The following is a description of a gene set: from publication Chen Y, Wang X (PMID 31504780) Human Gene Set: MIR10527_5P species: Homo sapiens Genes predicted to be targets of miRBase v22 microRNA hsa-miR-10527-5p in miRDB v6.0 with MirTarget v4 prediction scores > 80 (high confidence targets)., and this is the list of marker genes: SHOC2, AEBP2, DMRTA2, MAP2K3, ST3GAL2, SH3BGRL2, NECAP2, RCC2, TRA2A, ANKS1B, NFAT5, CXXC4, PIGA, CHL1, SPIN1, CTTNBP2, RAB3C, GLRA2, MLEC, GABRB2, KCTD9, ARPP19, C2CD6, TMEM201, CNTN4, FAP (fibroblast activation protein alpha), C2orf69, PARVA, C5orf15, LRTM1, KICS2, KDM7A, CUX1 (cut like homeobox 1), FLVCR1, MYOZ2, SAMD9L, MCM6, TNRC6B, EXOC5, DSTN, NRIP1, SP1, PRR14L, ZNF17, PTP4A1, POLR2K, MYLK4, SH3KBP1, SLC6A6, SUDS3, CACNA1C, FBXW8, SIPA1L2, PDE10A, AAK1, SLC25A24, FIBIN, USP34, TBC1D9, HSPH1, LONRF1, B3GNT5, SSTR1, SGIP1, TMTC4, BOLL, SPTSSB, BET1, ZNF445, FOS, CADM2, SLC2A2 (solute carrier family 2 member 2), CNTRL, OGFRL1, ATXN3, ASTN1, PKD2L2, GTF2H5, VAV3, ATP2A2, SAXO2, TOX3, KLF6, ANKRD50, PPP1R9A, MN1, ZC3HAV1L, DUT, ABHD2, BARX2, DPY19L1, TRDN, STON1, PCNX1, AFF1, ZFR, NIPSNAP3B, USP42, PJA2, PHF14, FSD1L (NCBI Gene Id 83856), TBRG1, SETD7, RO60, SCAI, PLS3, SFT2D1, FRMD6, PROX1, BMI1, B4GALT6, SEMA3E, CTTNBP2NL, LAPTM5, C14orf39, PELI1, LMO7, PBX3, APAF1, CMTM6, HAT1, TAFA2, EPS8, SBNO1, ADAM10, CYP7A1, CMPK1, NIBAN1, IDS, PMP22, IRF2BPL, CSNK1G3, MACC1, TUSC3, LMO3, FAM53C, IRF2BP2, ZMAT3, CCDC18, ERAP1, ELAVL1, TMEM248, MSRB3, SLITRK4, ZFAND5, SDC1, ADAMTS6, IRF6, FGFR2, LBR, PRICKLE2, RPS6KA6, LAMP2, SUSD6, ZFP91, RFX3, CDK17, APOL6 (apolipoprotein L6), HYCC2, DCP2, PKHD1, NAV1, CSTF2, GRIA2, AKAP11, TRPC5, GTF2A1, SMIM14, PILRB, DOCK11, MS4A7, AGPAT5, SEPTIN11, CLEC3A, SLC35B4, RNPS1, SELENOF, MAP2K1, SPICE1, STK17B, MAST4, PREPL, COLEC11, FAM72A, STOML3, MYBL1, FSTL1, DNM3, UBE2K, ADNP, NAP1L4, ESCO2, ZNF527, TNIP1, ESRRG, PPM1D, PAN3, KCNK10 (potassium two pore domain channel subfamily K member 10), MAP3K2, MIGA1, TET3, NEBL (nebulette), HLA-DOA, SURF4, TNF, KCNJ5-AS1, OSBPL6, CMPK2, PCGF5 (NCBI Gene Id 84333), LIN54 (NCBI Gene Id 132660), C1orf56, OPTN, ITPRIPL2, ADNP2, MARCHF6, PLAGL2, MAFB, HNRNPD, UBE3A, CLIP4, ZIK1, PTGFRN, PPP3R1, C1RL, APPL1, BCL11B, CTBS, KATNBL1, MTMR10, CCDC88A, MTF1, GOSR2, CTCF (NCBI Gene Id 10664), HIVEP2, MYOCD, MBNL1, KSR1, MAF, IDE, CELF2, PRRX1, LRRN1, DOCK4 (dedicator of cytokinesis 4), SBSPON, ZNF319, PXK, BAMBI, TOR1AIP2, VPS13C, SRPK2, SELENOT, UBP1, CASP8AP2, YBX3, SOBP, KERA, RAB22A, HAUS2, SEC61A1, PGR, ZNF367, DAB2IP (DAB2 interacting protein), MCTP2, PLCXD3, RYBP, CNOT6, TIAL1, CA5B, FAM72C, ZNF267 (zinc finger protein 267), UCMA, TAFA1, ZNF407, FAN1, FAM72D, PURA, SPATS2L, MKLN1, CERT1, TENT5A, TCAIM, MEF2C, RAB14, TAF12, CSDE1, ANKRD63, RAB18, POLR2M, ZFHX4, EAF1, POLR1F, IPPK, CFAP300, PPP1R1C, PHACTR2, EGR4, PMP2, STK39, MAPK1, WAPL, SNX16, KCND2, CERS3, FAM72B, AMMECR1, CDK14, YOD1, CBLN1, ADRA1A, EZR, PPIC, RMND5A, NR4A3, RNF19A, GCOM1, STXBP5, GAD1, LRIG2, ETV1 (NCBI Gene Id 221810), SYPL1, MRAP2, ONECUT2, PRDM1, ACER3, CDH12, DGKG, THBS1, USP24, TMEM243, PAPOLA, DTNA, SYNJ2BP, PLXDC2, ZNF704, DENND1B, MID1, SORBS2, COMMD3-BMI1, TSHZ3, TXLNG, CDKN1B, MBD2, CFAP91, NRG1 (neuregulin 1), NAA50, MON2, CA8, ZNF404 (NCBI Gene Id 342908), LACTB2, DIP2A, LZTS1, IP6K2, MIER1, EBF2, CDK2AP1, BPTF (bromodomain PHD finger transcription factor), MFAP3L, CEP57, SLC6A4, ERCC6, AMER2, MATN3, PATE3, RXRA, SLC19A2, M6PR, IGF1, HDAC7, TSPYL5, KCNA5, SLC38A9, GDAP2, TM7SF3, SRSF6, RABGAP1, MECP2, BBS2, ROCK2 (NCBI Gene Id 9475), LUC7L2, POLR3E, DNAJB4, APH1B, AKAP12, SNX3, ST8SIA3, TNPO1, NF1, ETV5, LIN7C (lin-7 homolog C, crumbs cell polarity complex component), CLLU1-AS1, ZC3H11A, ATP6V1C1, NGDN (NCBI Gene Id 338007), RSBN1, PUS1, MMP16, STOX2, PCDH18, TCEAL8, USP33, CCND2, BBX, CETN1, CCND3, HELZ, CEBPZOS, FGFR1, KIF16B, WDR26, PPM1L, RNGTT, TMEM167A, SLC6A15, CNTNAP2, SLC25A15, ZBTB21, FBXL17, ACADM, EXOG, TBC1D1, IFNA16, PUM2, PIP4P2, HIPK3, KMT2E, CDC73, SKIL, KCNT2, SH3GL3, RBM27, RBM12, SLCO3A1, SUPT7L, SEC22B, FAM98A, GABRB3, ZDHHC21, EIF1AX, PKP1, BLOC1S6, DLG2, GPATCH8, ORC1, PIAS2, WASF1 (NCBI Gene Id 8936), BACH2, SRSF2, RRP15, RAB8B, ARPP21, MINDY2, IQCJ-SCHIP1, KCNAB1, PITPNC1, SLC30A1, FAM171A1, PGGT1B, LATS2, DCLK1, SLX4IP (NCBI Gene Id 140682), VGLL3, CNKSR2, SEL1L, STC1, ZNF662, SLC9A9, CHMP2B, ZBTB10, PTPRM, MNDA, ZBTB43, TBL1XR1, MAPK1IP1L, PRIM2, NOL4 (nucleolar protein 4), FOXP1, SRP19, GRIA3, IGF2R, SCP2, CDK12, RAB10, EPM2AIP1, TRAPPC3L, SCHIP1, BRD1, DYRK1A, ATF2, TET2, GIMAP4, CNTN5 (contactin 5), KDM5A, SEC23A, HIBADH (NCBI Gene Id 221893), BNC2, TMEM30A, MAGEF1, ELL2, CCNYL1, CACNB4, MAP4K5, CCP110 (NCBI Gene Id 9738), PHLDA1, SLC38A1, AHR, CDH11 (cadherin 11), CD2AP, HIPK1, VPS37A, ZBTB20, IL22RA2, SYBU, NUFIP2, QKI, ATG2B, ZNF143, DDAH1, SATB1, ALKBH2, PDGFC, ACBD5, PKIB, FSTL5, KITLG, EIF4E, ACTL6A, KMT5A, DMXL2, MEOX2, ABI1, TRIM2, SSH2, PKIA, ARL5A, WDFY3, ACSL4, HSF2, EIF5, ASB5, NHLRC2, KCNV1 (NCBI Gene Id 27012), MCL1, PRPF40A, CACUL1, ROBO2, PLP1, EVL, CD109, MIDEAS, GALNT13, SPIN3, MASTL, SH3RF1, CHRDL1, COL17A1, CHM, SMC1A, NCAM1, UBE2V1, CEBPA (CCAAT enhancer binding protein alpha), RC3H1, CCDC186, ZNF652, SLC10A7, TPRG1, ZNF326, WDR20, GPBP1, ABCC9, LBH, INO80D, JAKMIP2, SLC17A6, MAP3K20, SECISBP2L, ABCF2, OSBP2, PGM5, DDHD1, CAMK4, TTPA, CPSF6, SNAP25, SLC16A7, BACE1, KDSR, GOLPH3 (golgi phosphoprotein 3), BRWD3, STRN3, UBN2, RAB11FIP2 (NCBI Gene Id 22841), NALF1, CALCRL